Given this list of marker genes Zfpm2, Trim3, Tcf7l2, Muc20, Sall4, here is a description of the gene set: Mouse Gene Set: MIR_541_3P Genes predicted to be targets of miRBase v22 microRNA mmu_miR_541_3p in miRDB v6.0 with MirTarget v4 prediction scores > 80 (high confidence targets). from publication Chen Y, Wang X (PMID 31504780) studied in species Mus musculus